Given this list of marker genes CSF2RB, SNX24, DSG2, HOXA7, UBALD2, SGSM3, FBXO27, TRMT9B, KIF1A, SCIN, CPLX1, FRY, RAD54L2, NKAIN4, TTLL13, TREM1, BEX4, WNT4, SLC12A7, GPM6B, C3orf62, TMEM214, CRABP1, RGS9, WDR26, UCN2, ACTR5, KRT33B, INVS, TPMT (thiopurine S-methyltransferase), ATP1A4, FAM131A, ARMC9, TFIP11, IGFBP2, SPHK1, ASTL, MED7, B4GALNT4, CENPT, CIDEC, CANT1, GFPT2, ATXN7L2, WRNIP1, GPR153, MGAT3, ADGRF5 (adhesion G protein-coupled receptor F5), ARHGAP39, GDF10, ANKRD52, AP5S1, TBC1D4 (TBC1 domain family member 4), ANO1, ZIM2, C11orf86, PAX4, AHRR (NCBI Gene Id 57491), DOCK6, P2RX1, IL20RB, DOK1, VXN, SLC35E4, RTN1, RCC1L, PLAC1, ISL2, CRTAC1, SHF, CELF3, PRMT8, GOT2, RPTN, ACAA2, KRT16, FN3K, LGALS12, HP, NEPRO, LHX1, ETV5, GNAT1, POM121L2, FANCB, SORL1, PALLD, RAB29, IL9R, FBXW9, NXPH3, FBXL2, IL12A, BBS10, ABCB10, MYO1A, CHST13, RASL10B, SCGB3A1, CCR8, PTGES3, MED22 (mediator complex subunit 22), SLAMF8, VGLL4, OLAH, SLC25A41, FGG, LY86, PRX, IL25, CGN, CFAP184, UBE2O, EIPR1, MOK, GOLM1, RINL, C17orf99, CACNG4, ABCC5, KLHL25, TNFAIP8L2, CLDN18, DHX32, MYORG, TMEM52, NUDT3, PHF24 (NCBI Gene Id 23349), RSAD2, TEKT2, DENND2A, COBLL1, HDGF, NHLRC1, DTD2, SPSB2, FXYD7, LHFPL4, PPIB, CMTM5, PPP2R2B, PPIP5K1, ALDH4A1, ESRRG, CDH5, FANCC, CREBL2, KMT5A, COL18A1, MT3, CCL5, MAP6D1 (NCBI Gene Id 79929), RHOV (NCBI Gene Id 171177), RTL8C, SGTA, CHST10, AP2A1, ZMYND10, NHSL1 (NCBI Gene Id 57224), ZBTB11-AS1, PEX5, MPPED2, HNF1A, CNGA1, TBX5, TYRP1, BYSL, GP1BB, CLDN3 (claudin 3), SOHLH2, RFTN1, NSD1, BTNL9 (NCBI Gene Id 153579), SLC35F6, TGFA, INPP5B, LRRC17, JPH2, AGBL4, SLC26A11, PDE6H, PHLDB1, NUP50, SLC13A4, TREH, GHSR, GGA1, FBXO32, PIM2, TDRP, KCNMB4, OPN1LW, ZNF580, SLC16A11 (NCBI Gene Id 162515), CACNA1S, NOC3L, KMT2C, PAPLN, GSDME, SH3KBP1, here is a description of the gene set: CD4(+)Foxp3(+) regulatory T (Treg) cells originate primarily from thymic differentiation, but conversion of mature T lymphocytes to Foxp3 positivity can be elicited by several means, including in vitro activation in the presence of TGF-beta. Retinoic acid (RA) increases TGF-beta-induced expression of Foxp3, through unknown molecular mechanisms. We showed here that, rather than enhancing TGF-beta signaling directly in naive CD4(+) T cells, RA negatively regulated an accompanying population of CD4(+) T cells with a CD44(hi) memory and effector phenotype. These memory cells actively inhibited the TGF-beta-induced conversion of naive CD4(+) T cells through the synthesis of a set of cytokines (IL-4, IL-21, IFN-gamma) whose expression was coordinately curtailed by RA. This indirect effect was evident in vivo and required the expression of the RA receptor alpha. Thus, cytokine-producing CD44(hi) cells actively restrain TGF-beta-mediated Foxp3 expression in naive T cells, and this balance can be shifted or fine-tuned by RA. Human Gene Set: GSE13306_TREG_RA_VS_TCONV_RA_DN from publication Hill JA, Hall JA, Sun CM, Cai Q, Ghyselinck N, Chambon P, Belkaid Y, Mathis D, Benoist C (PMID 19006694) Genes down-regulated in regulatory T cell (Treg) treated with retinoic acid (tretinoin) versus conventional T cells. studied in species Homo sapiens